Given this list of marker genes VPS25, GEMIN4, PRPF40A, LPP, SIGLEC1, CCSAP, OAZ3, IQUB, KLRK1, GNG13, PKP1, CLSTN2, ISL1, GOT2, STMN4 (stathmin 4), IGSF5, PCDH19, CDK12, OPRM1, CLIC4, GPR61, SPMIP6, GRAMD1C, DGKK, MLF2, DIXDC1, GSG1L, INAFM2 (InaF motif containing 2), BRD4, CALHM1, MTHFD2L, CASP10, PPP3CA, SSBP2, MRPS14, BHMT, TFDP2, FAM169BP, LRRC27, SLC25A21, LARP1, ELAVL2, PSEN1, WDR77, DCTN4, STAC, RNF157, RNF144A, DBNDD1, REPIN1, FIBIN, NFASC, NSD2, NOVA1, SMYD1, RABL2B, AFAP1L1, ZDHHC22, BLOC1S3, MFAP3L, TGM2, NPY, MYOZ1, RABL2A, BTAF1, CALCB, IQSEC3, TLDC2, CALCR, HNRNPU, SMURF2, B9D1, FGFR1OP2, here is a description of the gene set: species: Homo sapiens from publication Chen Y, Wang X (PMID 31504780) Human Gene Set: MIR2392 Genes predicted to be targets of miRBase v22 microRNA hsa-miR-2392 in miRDB v6.0 with MirTarget v4 prediction scores > 80 (high confidence targets).